The following is a description of a gene set: species: Mus musculus Mouse Gene Set: REACTOME_EPHA_MEDIATED_GROWTH_CONE_COLLAPSE EPHA-mediated growth cone collapse, and this is the list of marker genes: Efna5, Epha8, Efna2 (ephrin A2), Rhoa, Fyn, Epha7, Yes1, Ngef, Efna1, Lyn, Epha10, Epha2, Efna3, Epha4, Epha1, Src, Efna4, Epha6